The following is a description of a gene set: Mouse Gene Set: REACTOME_GLUCONEOGENESIS studied in species Mus musculus Gluconeogenesis, and this is the list of marker genes: Pgam1 (phosphoglycerate mutase 1), G6pc2, Slc37a2 (solute carrier family 37 (glycerol-3-phosphate transporter), member 2), Slc37a1, Aldoc, Pck2, G6pc1, Eno2, Gapdhs, Pgam2, Eno3, Pck1, Aldob, Pgk1, Aldoa (NCBI Gene Id 11674), Eno4, Gpi1, Tpi1, Pcx, Pgk2, Slc37a4, Gapdh, Fbp2, G6pc3, Fbp1